The following is a description of a gene set: Genes specifically down-regulated in pediatric acute lymphoblastic leukemia (ALL) patients by high-dose methotrexate (HDMTX). To elucidate the genomics of cellular responses to cancer treatment, we analyzed the expression of over 9,600 human genes in acute lymphoblastic leukemia cells before and after in vivo treatment with methotrexate and mercaptopurine given alone or in combination. Based on changes in gene expression, we identified genes that accurately discriminated among the four treatments. Discriminating genes included those involved in apoptosis, mismatch repair, cell cycle control and stress response. Only 14% of genes that changed when these medications were given as single agents also changed when they were given together. These data indicate that lymphoid leukemia cells of different molecular subtypes share common pathways of genomic response to the same treatment, that changes in gene expression are treatment-specific and that gene expression can illuminate differences in cellular response to drug combinations versus single agents. from publication Cheok MH, Yang W, Pui CH, Downing JR, Cheng C, Naeve CW, Relling MV, Evans WE (PMID 12704389) species: Homo sapiens Human Gene Set: CHEOK_RESPONSE_TO_HD_MTX_DN, and this is the list of marker genes: H3-3B (NCBI Gene Id 3021), SEC22B, ALDH5A1, PARG, HIC2, CRYZ, KATNB1, NRXN2, CEP170, STRAP, BNIP3L, ARF4, TOB2, SOCS2, NUP98, DYRK1A, MAPK1IP1L, TGIF1, ABRAXAS2, RALBP1, CNOT8, AP1S2, ZBTB1